Given this list of marker genes PRKCB, SPHK1, PRKCA, NRAS, PDPK1, PRKCD, SRC, ITPR3, ITPR2, AHCYL1, PLCG1, RASA1, PRKCZ, KDR, VEGFA, KRAS, ITPR1, HRAS, CALM1, here is a description of the gene set: Reactome Pathway: VEGFR2 mediated cell proliferation part of: VEGFA-VEGFR2 Pathway studied in species Homo sapiens VEGFR2 stimulates ERK not via GRB2-SOS-RAS, but via pY1175-dependent phosphorylation of PLC gamma and subsequent activation of PKCs. PKC plays an important mediatory role in the proliferative Ras/Raf/MEK/ERK pathway. PKC alpha can intersect the Ras/Raf/MEK/ERK cascade at the level of Ras or downstream of Ras through direct phosphorylation of Raf. VEGF stimulation leads to Ras activation in a Ras-guanine nucleotide exchange factor (GEF) independent mechanism. It rather relies on modulating the regulation of Ras-GTPase activating protein (GAP) than regulation of Ras-GEFS.